The following is a description of a gene set: from publication Szanto A, Balint BL, Nagy ZS, Barta E, Dezso B, Pap A, Szeles L, Poliska S, Oros M, Evans RM, Barak Y, Schwabe J, Nagy L (PMID 21093321) Human Gene Set: GSE25088_CTRL_VS_IL4_STIM_MACROPHAGE_DN Genes down-regulated in wildtype bone marrow-derived macrophages: control versus treated with IL4. studied in species Homo sapiens C57Bl/6 wild-type and STAT6 KO mice were used to study PPARg and IL-4 signaling. Bone marrow of 3 mice per group was isolated and differentiated to macrophages with M-CSF (20 ng/ml). 20 ng/ml IL-4 was used to induce alternative macrophage activation and 1 uM Rosiglitazone (RSG) was used to activate PPARg. From each mouse 4 samples were generated: 1. M-CSF, 2. M-CSF+RSG, 3. IL-4 and 4. IL-4+RSG. All compounds were added throughout the whole differentiation process, and frech media was added every other day. Control cells were treated with vehicle (DMSO:ethanol). After 10 days, RNA was isolated and gene expression profiles were analyzed using Mouse Genome 430 2.0 microarrays from Affymetrix., and this is the list of marker genes: MOB3C, LTB4R, EML3, BCLAF1 (NCBI Gene Id 9774), NAT10, OCEL1, TJP2, AGTRAP, MAN2A2, FAM149A, ENSG00000267882, DLGAP1, CRACDL (NCBI Gene Id 343990), TBC1D2, ICA1, VPS39, ADD1, APPL2, ZBTB49, TBC1D25, BLOC1S1, AARS2, CBLB, EIF4EBP1, TMA16, ENSG00000285566, DYNLT5, MYBPC3, ADAM8, ARHGEF7, ARNT2, TPCN1, XPO7, ZNHIT2, ZNF697, AP5B1, FLG, ROM1, TEX35, C19orf67, C2orf42, NUMA1, H6PD, SH3RF1, LRRC39, LINC00612, PLXDC2, C1orf174, MOCOS, DCAF6, ANGPTL2, IL1R1, SLFNL1, ST3GAL1, POLK, TMEM219, NT5M, BCL2A1 (NCBI Gene Id 597), SNX17, GNA11, GPR152, SNX33, SBSN, DAND5, VAMP2, NME6, FIGN, C1orf141, TMBIM1, ID4, CD160, DYNLT1, GDI1, ZNF579, CHRNA6, KLHL4, MAB21L4, ZNF687, IL18R1, SRGAP3, PABPC1L, POU6F1, SHFL, ZDHHC12, IRF2BP1, RFXAP, CARNS1 (carnosine synthase 1), NFATC4, CRYBG2, MAMDC4, PRDM5, MAFK, RHOD, MUC1, DGAT1, DTX3, H1-7 (H1.7 linker histone), HEXIM2, ZZEF1, C1orf50, WDFY2, PAQR7, NCAM2, ERMN, CD7, KIAA0319L, VWA3B, ANGPTL8, RASGRP4, TEK (NCBI Gene Id 7437), MEI1, TDRKH, COPG1, ZNF76, ZNF219, ITGB1BP2, LGALS3, TNFRSF1B, TNFRSF14, LAG3, S100A1, HIP1, NUPR1, NOTCH1, KCTD17, RBFA, CDIP1, CARD19 (caspase recruitment domain family member 19), SLC32A1, PLA1A, GIGYF1, C4B, PAQR8, EPN1, TMEM25, TYK2, RXRB, FAM20A, CARF, MIGA2, SMAD6, EXT1, C4orf33, AGER, MYH9, CACNB4 (calcium voltage-gated channel auxiliary subunit beta 4), CHRNA9, SLC37A2, RPS6KB2, GSTT1, MAPK3, OAS2, ZAN, MARVELD1, NPLOC4, NR4A1, SLC24A3, MAPK7, SPHKAP, TBC1D2B, ACTL7B, PDCL2, PLCB4, CST7, TRPM6, RAB43, GDPD2, SRRD, NEK8, AXIN2, LGALS4, RNF182, GLRA2, COTL1, SLC9B2, TONSL, C1orf122, PRDM16, PSMA5, GRK6, AKAP1, C8orf74, SLC29A2, SPHK2, AMOTL1, PHAF1, RAPH1, RANBP10, DISP1, CCT8L2, PEX11A, SPA17 (sperm autoantigenic protein 17), PRICKLE2, OPCML, MINDY1, CLDN15, FAM81A, IRAG2, MFGE8, TGFBRAP1 (NCBI Gene Id 9392)